Given this list of marker genes Cyp3a13, Ggt5, Dpep2, Cyp3a11, Acy1, Akr7a5, Ggt6, Ggt7, Cyp3a16, Mgst3, Cyp3a25, Cyp3a41a, Mgst2, Ggt1, Cyp1a2, Dpep1, Mgst1 (NCBI Gene Id 66600), Acy3, Cyp3a59 (NCBI Gene Id 100044462), Cyp2a5, Cyp3a57, Cyp3a44, Cyp3a41b, here is a description of the gene set: Mouse Gene Set: REACTOME_AFLATOXIN_ACTIVATION_AND_DETOXIFICATION Aflatoxin activation and detoxification species: Mus musculus